The following is a description of a gene set: The process of restoring mitochondrial DNA after damage. species: Homo sapiens Human Gene Set: GOBP_MITOCHONDRIAL_DNA_REPAIR, and this is the list of marker genes: PRIMPOL, PARP1, DNA2, TP53, LIG3, MGME1, NEURL4